The following is a description of a gene set: Mouse Gene Set: GOBP_REGULATION_OF_TYPE_II_HYPERSENSITIVITY species: Mus musculus Any process that modulates the frequency, rate, or extent of type II hypersensitivity., and this is the list of marker genes: Fcgr3 (NCBI Gene Id 14131), Fcer1g, C3, Fcgr1, Ighg1, H2-T23, Ighg2b (NCBI Gene Id 16016)